The following is a description of a gene set: Human Gene Set: HP_CHRONIC_COUGH Chronic cough A persistent cough, defined as a cough lasting longer than eight weeks in adults or longer than four weeks in children. species: Homo sapiens, and this is the list of marker genes: DNAAF4, AGR2, DAW1, RELB, CFAP74